Given this list of marker genes GHRL, ECRG4, APLN, AQP1, CRHBP, UCN, CRH, RAB8B, CRHR1, here is a description of the gene set: The regulated release of corticotropin by a cell. Corticotropin hormone is a polypeptide hormone synthesized and secreted from corticotropes in the anterior lobe of the pituitary gland in response to corticotropin-releasing hormone (CRH) released by the hypothalamus. studied in species Homo sapiens Human Gene Set: GOBP_CORTICOTROPIN_SECRETION